The following is a description of a gene set: studied in species Homo sapiens Human Gene Set: GOBP_GAMMA_AMINOBUTYRIC_ACID_SECRETION The regulated release of gamma-aminobutyric acid by a cell or a tissue. The gamma-aminobutyric acid is the principal inhibitory neurotransmitter in the brain but is also found in several extraneural tissues., and this is the list of marker genes: NF1, GABBR1, TRH, ABAT, BEST1, NTSR1, P2RX7, TRPC4, APBA1, CACNB4